Given this list of marker genes Pbx2, Pafah1b1, Cxxc5, Gm8267, Snrpd1, Wnt5a, Ldlrad3, Fbxl17, Far1, Cnot6 (CCR4-NOT transcription complex, subunit 6), Otud7b, Immt, Mtrr, Firrm, Lrrtm4, Onecut2, Trip11 (thyroid hormone receptor interactor 11), Thsd7b, Depdc1b, Slc6a1, Mblac2, Ccl9, Zfp503, Cdh11, Ddx17 (DEAD box helicase 17), Gngt1, Tet1, Apbb2, Ercc8, Ctso, Tcerg1, Tmem132b, Qtrt2, Ube2t, Nfat5, Szrd1, Tfcp2l1, Ibtk, Cxcr4, Abcb1a, Ccbe1, Rora, Mier1, Nfib, Mex3a, Asb7, Meak7, Pcdh7, Gtf2a1, Fcgr4, Hapln1, Enah, Crkl, Cask, Thap1, R3hdm2, Golph3, S1pr3, Ptpn21, Dock4, Phf8, Prtg, Lrp6, Luc7l, Cdh1, Eif5a2, Qdpr, Mcu, Nrxn3, Wif1, Cygb, Cherp, Ank3, Fut11, Fam3c, Tcstv7a, Synpo2, Camk2a, Kif1b, Mysm1, Ddx19b, Igf1r, Adra1a, Prb1b, Extl1, Calm2, Prickle3, Arid5b, Map3k2, Fgfr3, Clvs2, Ptprc, Kazn, Atp2b1, Cln8, Tcf4, Cacna1c, Ptbp2, Ino80d, Sall3, Emc3, Ttll7, Pnoc, Psmf1, Aard, Dapp1, Bcl2l12, Nup153, Tyms, Entrep3, Afap1, Marchf4, Large1, Gdi2, Itgav, Btbd8, Mmgt1, Exph5, Socs5, Pcdh8, Nlrp4a, Med12l, Zfand5, Scn8a, Kbtbd11, Sgk1, Fam161b, Pax9, D6Ertd527e, Hp1bp3, St3gal4, Wnk3, Tlcd4, Homer2, Gpr158 (NCBI Gene Id 241265), Ranbp6, Atl2, Cwf19l2, Hnf4g, Sgms1, Sipa1, Bdp1, Spag9, Akap5, P2ry1, Slc15a1, S100pbp, Asb15, Sall1, Patl2, Galc, Prkx, Sdr16c5, Sox5, Kmt2a, Arl14, Kif26b, Smtnl2, Phf20l1, Ereg, Cyp3a41b, Tmprss11c, Terf1, Ddx39b (NCBI Gene Id 68389), Ift140, Adamts5, Lepr, Cds1, Stxbp5, Lypla1, Ace2, Gfra2, Runx3, Uri1, Foxp2, Hnrnpd, Tbx18, Pde10a, Lsm6, Acsf2 (NCBI Gene Id 264895), Tsen34, Arhgap19, Tanc2, Cd200r4, Tpbg, Serinc1, Scn3a (sodium channel, voltage-gated, type III, alpha), Dstyk, Ccdc93, Slc23a2, Vsig10l, Htr1a, Bltp1, Rflnb, Gpm6a, Rbpj, Rac2 (Rac family small GTPase 2), Tmx4, Srp54b, Ctnna3, Adcy9, Sgms2, Stxbp6, Tppp, Zfp407, Shisa9, Hectd2, Zic5, Mllt3 (NCBI Gene Id 77576), Elf2, Faf1, Ppp6c, Ccdc6, Matn1, Akap6, Vps13d, Reps2, Tacstd2, Slc18a2, Ywhab, Setd7, Slc10a4, Ncoa1, Tnrc6c, Smad2, Sec63, Rfx8, Ptpru, Naa35, Rras2, Slc22a23 (solute carrier family 22, member 23, NCBI Gene Id 73102), Dtx3l, Rilpl2, Calml3 (calmodulin-like 3), Preb, Ttc14, Foxo1, Syt4, Trpc5, Qki, Fbxw7, Gvin2, Ppih, Mark2, Chml, Grip1, Septin7, Cdk1, B3galt6, Tfdp1, Cks2, Slitrk5, Ptbp3, Chn2, Med28, Pip4p2, Calb1, Dhx9, Dnajc6, Dusp10, Fhdc1, Snca, Sycp3, Aebp2, Thbs2, Ntrk2, Neo1, Piezo2, Jarid2, Ptpn2, Nufip2 (NCBI Gene Id 78671), Ccrl2, Lgr4, Jun, Spryd7, Pou2f1, Tmem263, Bloc1s2, Runx1t1, Dennd2c, Bpnt1, Msx2, Dcp2, Fam91a1, Gpat3, Apod, Ammecr1l, Bclaf1, Cstf3, Kif1c, Zic3, Cyp3a41a, Slc7a2, Sgcz, Tdrd5, Kalrn, Asb8, Tbl1xr1, Slc7a11, Ptchd4, Ube2d2a, Smc6, Cd274, Mdn1, Fat1, Gja8, Lamtor1, Heatr5a, Mtss1, Arid4a, Vav2, Ell2, Sash1, Dach1, Ubap1, U2surp, Pstpip2, Tmc7, Ptma, Ptk7, Rcan2, Sgcb, Nr4a3, Deptor, Eif2s3x, Fign, Pspc1 (paraspeckle protein 1), Prom2, Chd1, Jam2, Ecm2, Zfp422, Mmp24 (NCBI Gene Id 99226), Cpeb2, Upf1, Nrp1, Sirt6, Pcbp2, Dgke, Poldip3, Fstl1, Gbx2, Bmx, Entpd7, Bcl6b, Ppp2r5a, Cdk17, Ttc19, Pde4c, Slc8b1, Wdr45b, Hnrnph1, Kcnip4, Col25a1, Six4, Tcstv2b, Cdk6, Mboat7, Znrf2, Kmt2c, Zbtb44, Bicd1, Klhl1, Asah1, Cbln2, Camta1, Tnrc6a, P2ry12, Nectin3, Ooep, Slc30a7, Gvin1, Chsy3, Celf2, Arl5b, Parpbp, Tmod2, Zfp101, Cts8, Hectd1, Fut9, Gabpb1, Itprip, C3ar1, Hbegf, Six6, Mc4r, Gpr4, Rmnd5a, Tfap2a, Ldlr (NCBI Gene Id 16835), Unc5c, Gucd1, Serpinb10, Usf3, Tcstv4, Mis18bp1 (NCBI Gene Id 97807), Dicer1, Irf2, Zbtb10, Ces2b (NCBI Gene Id 234669), Med1, Rnd3, Tob1, Sntg1, Gca, Ppp1r3a, Ppm1k, Sybu, Ankle2, Sumo1, Myo1b, Gab3, Socs7 (suppressor of cytokine signaling 7), Fnip1, Cpeb3, Agl, Arid1b, E4f1, Mpv17l, Phlpp1, Hycc2, Samd8, Semp2l1, Plekhm3, Mitf, Ipmk (NCBI Gene Id 69718), Ptprf, Iws1, Mrfap1, Kctd12, Nwd2, Virma, Speer4b, Gpr107, Erich5, Il19, Asap2, Arrdc3, Zfr2 (NCBI Gene Id 72078), Etnk1, Entpd4, Myocd, Dap3, Vwc2l, Nip7, Pcdhb7, Zfand1, Bmp5, Osbpl8, Pogk (NCBI Gene Id 71592), Tcstv5a, Mrpl35, Grb2 (growth factor receptor bound protein 2), Fbxo30, Bcat1, Esyt2, Primpol, Slain2, Bnip3, Tcp10c, Gpr183, Zbtb41, Washc4, Notch2, Slc7a6, Neu3, Wdtc1, Nr3c1, Rest, Slc25a51, Onecut3, Zbtb34, Lrch3, Adam19, Hira, Cnot6l, Parp11, Nop16, Tnpo1, Cxxc4, Fgfr1, Ccn1, Hdgfl3, Zcchc24, Reep3 (receptor accessory protein 3), Il1rl1, Tor1aip2, Apln, Nbea, Psmd11, Celf1, Sorcs1, Rarb, Csn1s2a, Strbp, Tsc22d3 (TSC22 domain family, member 3), Tox3, Hirip3, Phlpp2, Fbn2, Scd4, Epb41l2, Rhobtb1, Rapsn, G2e3, Elmod2, Gmeb1, Wwp1 (NCBI Gene Id 56840), Cep97, Mllt11, Tm4sf20, Fli1, Zmynd19, Scai, Camsap2, B4galt7, Cadps2, Gpr12, Plcb3, Bnip5, Pphln1 (NCBI Gene Id 69779), Fbxo22, Irs4, Metrn, Bdnf, Trhde, Lnpep, Polr3b, Paqr6, Cyp2u1, Marf1, Tcstv2a, Maml3, Zfp345, Vps39, Dmp1, Zmat1 (NCBI Gene Id 215693), Slc40a1, Nap1l1, Zfp318, Septin8, Mbtd1, Mylk, Ipo5, Ifnar2, Adrb2, Frmd7, Zfp326, Cct8, Map4, Fam76a, Fbxw2, Lzts2, Lhfpl6, Sdf2l1, Trim44, Zbtb7a, Rictor, Itga6 (NCBI Gene Id 98854), Mef2a, Klhl4, Cdk7, Arpp21, Gria2, Map4k5, Zfp799, Ift80, Cyria, Tshz3, Cers6, Gtf3c3, Tfam, Rprd2, Poglut3, Clta, Zfp763, Nlgn1, Zfp113, Arhgef33, Rb1cc1, Hspa5, Il23a, Hoxd9, Naa30, Kcnma1, Sowahc, Ncoa2, Sec22b, Sestd1, Get1, Vangl2, Rbm27, Kcnc2, Slc16a1, Sema3d, Rrp1b, Khdrbs2, Usp25, Chl1, Grm7, Slc8a1, Oprm1, Wdr25, Atp6v0b, Gna14, Mylk4, Klhl15, Sfxn3, Hook3, Naaladl2, Ppp1r14c, Erlin2, Dynlt3, 4930544G11Rik, Bri3bp, Tmem87b, Pou3f2, Ccnjl, Etv1, Fbxo3, Rnf169, Sin3b, Hivep2, Macf1, Mbnl1, Azi2, Zcchc10, Ct55, Ewsr1, Srsf10, Rexo1, Nucks1, Rnf44, Fbxo4, Cldn34c1, Msi2, Mb21d2, Nectin1 (NCBI Gene Id 58236), Mga, Ccp110 (centriolar coiled coil protein 110), Psg16 (pregnancy specific beta-1-glycoprotein 16), Espnl, Neurod2, Lonrf3, Klhl5, Lgmn, Hdac9, Gm4894 (predicted gene 4894), Esrrg, Neurod1, Rabgap1, Prickle2, Apol10b, Hbp1, Shisa2, Gna13, Gata3, Otol1, Ski, Cebpg, Cacul1, Ebf2, Ube4a, Ube2w, Ccnd2, Steap2, Rapgef2, Fgf10, Hoxa10, Cfap20, Neu1, Eif2b1, Cmtm6, Trmt9b, Pik3ca, 9330159F19Rik, Spock3 (sparc/osteonectin, cwcv and kazal-like domains proteoglycan 3), Tcstv3, Zhx3, Ugcg, Syt6, Tasor, Noc2l, Ptpre, Alg6, Lpgat1, Ap1g1, Cdc42, Elavl4, Spr, Slc35a5, Smc5, Rasl2-9, Med18, Kif21a, Tulp4 (NCBI Gene Id 78646), Pank3, Tmub2, Tbx3, Elovl7, Ffar4, Il17re, Slc35f1, Boc, Cbx6, Acer3, Yes1, Brms1l, Ctla4 (NCBI Gene Id 12477), Irf2bp2, Riok3, Kras, Ppp1cb, Ddx3x, Pds5b, Fsd1l, Taok1, Ncor1, Dennd2b, Dennd6a, Fbxl14, Cep170, Jade1, Tfap4, Fzd6, Dhcr7, Myod1, Polr3gl, Adarb2, Pkia, Cited2, Ctnnd1, Sppl2a, Kdm5a, Zc3hav1l, Pcyox1l, Aplp2, Adra2b, Igfbp5, Tnrc18, Mmp20, Csnk2a2, Tspan31, Pex13, Cflar, Uhmk1, Vamp2, Asph, Mafb, Smad5, Zc3h14, Hepacam2, Tcstv2c, Lhfpl7, Msantd3, Cnot2, Arl8a, Gse1, Eeig2, Trio, Fbxo32, Hs3st5, Or2v1, Edn2, Peli2, Ero1b, Nbeal1, Mthfd2 (methylenetetrahydrofolate dehydrogenase (NAD+ dependent), methenyltetrahydrofolate cyclohydrolase), Bmi1, Slc18b1, Zfp106, Klf12, Rai2, Tob2, Adk, Supt16, Phf2, Zmym2, Reep1, Abraxas1, Ppp2r5e, Armc2, Megf10, Tgif1, Slit2, Phf14, Cpsf6, Arb2a, Rere, Tmem170, Nmrk1, Elavl1, 5730480H06Rik, Ccdc71l, Zfp26, Hykk (NCBI Gene Id 235386), Selenbp2, Zic1, Cdc37, Zmat3, Sipa1l2, Cutal, Bcl11b, Chd9, Utp4, Pcdhb16, Kdm4c, Zfhx3 (NCBI Gene Id 68160), Cnksr2, Bptf, Nr4a2, Crebrf, Pcdh11x, Acvr2b, Nup107, Nrp2, Nfya, Ctbp1, Seh1l, Trps1, Hipk1, Ythdc1, Syn2, Grm5, Prdm1, Plek, Ubtd2, Yme1l1, Rorb, Plaur, P2ry4, Agps, Itfg2, Trim6, Aggf1, Gm5148, Fbln1, Nlrp3, Cnnm3, Erich1, Tnr, Unc45b, Nuak2, Cnbp, Zbtb21, Sdr9c7 (NCBI Gene Id 70061), Pkp4, Satb1, Brd1, Creb1, Ercc6, Chic1, Ifnlr1, Gmip, Semp2l2a, Sirt1, Impa1, Orai2, 6030458C11Rik, here is a description of the gene set: species: Mus musculus Genes predicted to be targets of miRBase v22 microRNA mmu_miR_8118 in miRDB v6.0 with MirTarget v4 prediction scores > 80 (high confidence targets). from publication Chen Y, Wang X (PMID 31504780) Mouse Gene Set: MIR_8118